The following is a description of a gene set: from publication Ben-Porath I, Thomson MW, Carey VJ, Ge R, Bell GW, Regev A, Weinberg RA (PMID 18443585) studied in species Homo sapiens Cancer cells possess traits reminiscent of those ascribed to normal stem cells. It is unclear, however, whether these phenotypic similarities reflect the activity of common molecular pathways. Here, we analyze the enrichment patterns of gene sets associated with embryonic stem (ES) cell identity in the expression profiles of various human tumor types. We find that histologically poorly differentiated tumors show preferential overexpression of genes normally enriched in ES cells, combined with preferential repression of Polycomb-regulated genes. Moreover, activation targets of Nanog, Oct4, Sox2 and c-Myc are more frequently overexpressed in poorly differentiated tumors than in well-differentiated tumors. In breast cancers, this ES-like signature is associated with high-grade estrogen receptor (ER)-negative tumors, often of the basal-like subtype, and with poor clinical outcome. The ES signature is also present in poorly differentiated glioblastomas and bladder carcinomas. We identify a subset of ES cell-associated transcription regulators that are highly expressed in poorly differentiated tumors. Our results reveal a previously unknown link between genes associated with ES cell identity and the histopathological traits of tumors and support the possibility that these genes contribute to stem cell-like phenotypes shown by many tumors. Human Gene Set: BENPORATH_MYC_TARGETS_WITH_EBOX Set 'Myc targets1': targets of c-Myc identified by ChIP on chip in cultured cell lines, focusing on E-box-containing genes; high affinity bound subset, and this is the list of marker genes: UBA52, CASP8, ASCL2, CEACAM5, H2AZ1, ELK1, ARF1, KLF1, RHOG, MELTF, NEFM, POLR3D, AMPD3, BCL2, PHB1, SRD5A1, RXRB, ATF4, GAPDH, HMBS, DKC1, H4C5, HNRNPA2B1, HBA2, HSP90AB1, FOXM1, PLK1, DCK, TGFB3, CCNB1, H4C15, RIDA, TXN, SLC4A2, TIMM17B, CBS, GAS8, AKAP1, IMPA2, MAGEA6, NHERF2, RPL19, RPS6, CFDP1, HMGN2, MET, MCM4, PARP1, BCL2L12, SRM, RPL10, IL11RA, ALDH2, MDM2, MCM7, CCND2 (NCBI Gene Id 894), ISG20, SURF6, PLA2G4A, CSTB, ETS2, MTHFR, BBC3, AMD1, QDPR, RPL13A (NCBI Gene Id 94020), PER1, PTGER2, EIF4E, AKR1A1, SMAD7, POLD2, CCND1, ACADM, FAH, EEF1A2 (NCBI Gene Id 6669), EIF5A2, TERT, BLK, AVP, ACE, SLC2A4, HDAC3, VAMP2, NTN3 (NCBI Gene Id 4917), IRF3, RCC1, ARSB, CDK4, ATF7, APEX1, RBM3, FASN, SLC19A1, JUN, FXN, HNRNPDL, UROD, POLB, GPR4, HERPUD1, NOTCH4, MUC1, AP4M1, BSG, ACOX1 (acyl-CoA oxidase 1), NTHL1, HNRNPA1, BRCA2, PSMA3, SERPINE1, PPP1R7, IRF2, CLCN6, ARF4, STMN1, HES1, H4C16, TCIRG1, PABPC1, DKK3, SIRT1, TOMM20, PEX3, CCKBR, TPM2, CDK10, CD2, E2F1, EBP, GSK3B, MSN, PPID, INSR, CEBPA, HBB, ID3, HBE1, IFRD2 (NCBI Gene Id 7866), NBN, PSEN2, HIF1A, HSP90AA1, ITGB1, APC, RPL23A, RGS2, ICAM1, HSPD1, RPL22, CLNS1A, NME1, MGST1, FOSL1, LBR, CTSF, PTMA, ACO2, MAGEA3, HSPA8, TOP1, WEE1, PDCD1, TGFB1, NOP2, VHL, MST1, FPGS, EGR3, PSMB1, NR1D1, WT1 (WT1 transcription factor, NCBI Gene Id 7490), MAN2A2, SNORD14C, BAX, ZFP36L2, TCF12, PIM2 (NCBI Gene Id 11040), FGFR4, SLBP, LMNB2, PAICS, STAT6, PRTN3, SNORD4A, RPS19, HSD11B2, MYCL, UCP3, RPS15, GALT, NIT1, MPO (myeloperoxidase), EIF4A1, RPL27A, SYNGR2, MNX1, TNFRSF8, ZNF146, PDHA1 (pyruvate dehydrogenase E1 subunit alpha 1), LMNA, SQSTM1, SIGMAR1, BCL3, TSC2 (NCBI Gene Id 7249), GOLGA7, TFRC, CHRNB1, SNORD32A, RARB, OCA2, APP, RPL36A, ACTB, SNHG5, PTEN, DBI, GALNS, NSUN2, CD63, ENO1, GLA, GSTP1, AMPD2, NCL (NCBI Gene Id 4691), ACTG1, JUNB, HBAP1, BMP4, CD79B